The following is a description of a gene set: species: Homo sapiens The mammalian Golgi complex, a central hub of both anterograde and retrograde trafficking, is a ribbon of stacked cisterna with biochemically distinct compartments. Anterograde cargo from the ERGIC and ER is received at the cis-Golgi, trafficked through the medial- and trans-Golgi and released through the trans-Golgi network (TGN) to the endolysosomal system and the plasma membrane. Although still under debate, current models of Golgi trafficking favour the cisternal maturation model, where anterograde cargo remain associated with their original lipid membrane during transit through the Golgi and are exposed to sequential waves of processing enzymes by the retrograde movement of Golgi resident proteins. In this way, cis-cisterna mature to medial- and trans-cisterna as the early acting Golgi enzymes are replaced by later acting ones. More recently. a kiss-and-run (KAR) model for intra-Golgi trafficking has been proposed, which marries aspects of the cisternal maturation model with a diffusion model of transport.<br>Like the anterograde ERGIC-to Golgi transport step, intra-Golgi trafficking between the cisterna appears to be COPI-dependent. Numerous snares and tethering complexes contribute to the targeting and fusion events that are required to maintain the specificity and directionality of these trafficking events. Golgi tethers include long coiled coiled proteins like the Golgins, as well as multisubunit tethers like the COG complex. These tethers make numerous interactions with other components of the secretory system including RABs, SNAREs, motor and coat proteins as well as components of the cytoskeleton. <br>Retrograde traffic from the cis-Golgi back to the ERGIC and ER depends on both the COPI-dependent pathway, which appears to be important for recyling of KDEL receptors, and a more recently described COPI-independent pathway that relies on RAB6. RAB6 and RAB9 also play roles at the TGN side of the Golgi, where they are implicated in the docking of vesicles derived from the endolysosomal system and the plasma membrane part of: Membrane Trafficking Reactome Pathway: Intra-Golgi and retrograde Golgi-to-ER traffic, and this is the list of marker genes: RAB18, VPS45, MAN1A2, KIF26A, KIF18A, GCC2, KIF5A, SURF4, TUBA1A, GOLGA1, DCTN5, KLC1, RAB39A, KIF3A, M6PR, KIF1B, TMED10, KIF9, NAA30, NAPB, TMED7, STX16, COPE (NCBI Gene Id 80158), TUBB8, TUBB3, ARFIP2, PLA2G6, CUX1, TUBB4B, VPS51 (VPS51 subunit of GARP complex), COPZ1, ARFGAP3, COG8, PAFAH1B1, KIF21A, COG6, GOLIM4, VAMP4, DCTN6, KIF4B, SNAP29, TUBA3D, TUBB4A, STX10 (NCBI Gene Id 8677), RAB30, ALPP, STX6, ARFRP1, KIF13B, KIF22, DYNLL2, BICD1, RAB6B, RAB1B, KIF21B, TUBA8, NAA35, MAN2A2, KIF26B, KIF2B, COG1, KIF11, KIF20B, TUBB1, COG5, TUBA1C, TUBA4A, CAPZA3, KIF15 (NCBI Gene Id 56992), TUBB8B (tubulin beta 8B), ARL1, RHOBTB3, PLA2G4A, PLIN3, KIFC1, DCTN3, SCOC, STX18, KIF1C, PAFAH1B3, RAB9A, NAPA, TUBAL3, RAB36, SYS1, BET1L, COPG2, KLC4 (NCBI Gene Id 89953), CAPZA2, GOSR1, KIF23, BICD2, KDELR2, KIF25, KIFC2, DCTN2, TMED9, KIF27, COPB2, RACGAP1, ARFGAP1, TUBB6, RAB33B (RAB33B, member RAS oncogene family), KIFAP3, TUBA1B, TMED3, KIF28P, DYNC1I2, IGF2R, PAFAH1B2, RABEPK, KIF12, NAPG, KIF16B, KLC3, KIF6, RIC1, KIF3C, KIF20A, TMF1, COPA, COG3, ACTR1A, RAB3GAP1, DYNC1LI1, USE1, ARCN1, KIF2C, VPS52, DYNC1H1, RAB9B, TUBB2A, TUBA4B (tubulin alpha 4b), KIF5B, VAMP3, MAN2A1, GCC1, VPS54, ARF5, NSF, ZW10 (NCBI Gene Id 9183), GOSR2, NBAS, TGOLN2 (trans-golgi network protein 2), KIF5C, RAB41, DCTN1, DCTN4, RGP1, CYTH1, COPB1, KIF2A (kinesin family member 2A), BNIP1, KIF4A, GBF1, STX5, USP6NL, AGPAT3, DYNC1I1, MAN1A1, DYNC1LI2, GALNT2, MAN1C1, TUBA3E, COPG1, GOLGA5, SEC22B, VPS53, ACTR10, COG4, RAB6A, TUBB2B, RAB43, KIF19, KIF1A, NAA38, KIF18B, DYNLL1, KIF3B, ARFGAP2, RAB3GAP2, GOLGA4, YKT6, KDELR1 (KDEL endoplasmic reticulum protein retention receptor 1), ARF3 (ADP ribosylation factor 3), RAB1A, CYTH2, GALNT1, VTI1A, KDELR3, RINT1, CYTH4, ARF4, COPZ2, CYTH3, TMED2 (NCBI Gene Id 10959), COG7, TUBA3C, COG2, ARF1, CAPZA1, CENPE, KLC2, TRIP11, CAPZB